The following is a description of a gene set: Mouse Gene Set: REACTOME_REGULATION_OF_MITF_M_DEPENDENT_GENES_INVOLVED_IN_PIGMENTATION studied in species Mus musculus Regulation of MITF-M-dependent genes involved in pigmentation, and this is the list of marker genes: Myo5a, Mapk14, Myrip, Usf1, Rab27a (RAB27A, member RAS oncogene family), Sytl2, Mlph